The following is a description of a gene set: Genes having at least one occurence of the motif GGCACAT in their 3' untranslated region. The motif represents putative target (that is, seed match) of human mature miRNA hsa-miR-455 (v7.1 miRBase). species: Homo sapiens Human Gene Set: GGCACAT_MIR455, and this is the list of marker genes: PLCXD3, TJP1, GDAP2, GABARAP, KCNJ2, NCK2, TNKS1BP1, PJA2, METTL17, RNF44, ATP11C, EDN1, ETS1, DDX3X, RTL9, TAF4, TOMM22, RPS6KB2, CERKL, GABRB3, PPP1R12A (protein phosphatase 1 regulatory subunit 12A), ADD3, WTAP, C4orf17, RIMS4 (NCBI Gene Id 200225), SNW1, TMED2, SOX6, HES5 (NCBI Gene Id 388585), BAZ2B, TMEM30A, DYNC1LI2, TNRC6B, USP3, CACNB4, SERP1, RANBP3, DCAF5, MYLIP, PAPOLG, SEMA4G, TRNP1, CPSF7, NLK, ERC2, RFX4, LUC7L3, ZIC3, NR4A2, TBC1D25, CFAP263, CDK14, DOCK9, SOX11, STX1B, CDK13, BRD1, SOCS3, SLITRK5